The following is a description of a gene set: studied in species Homo sapiens TRESK subfamily of tandem domain K+ channels has one only member. TRESK is regulated by Ca/calmodulin dependent protein phosphatase, calcineurin. Reactome Pathway: TWIK-related spinal cord K+ channel (TRESK) part of: Tandem pore domain potassium channels, and this is the list of marker genes: KCNK18